The following is a description of a gene set: Catalysis of the reaction: 3-chloroallyl aldehyde + H2O = 2 H+ + 2 e- + 3-chloroacrylic acid. Human Gene Set: GOMF_3_CHLOROALLYL_ALDEHYDE_DEHYDROGENASE_ACTIVITY species: Homo sapiens, and this is the list of marker genes: ALDH3A1, ALDH3A2, ALDH3B1, ALDH1A2, ALDH3B2